Given this list of marker genes Psmb4, Psmd2, Psmd7, Maml3, Psmd3 (proteasome (prosome, macropain) 26S subunit, non-ATPase, 3), Psma3, Lef1, Yap1, Psmb2, Tcf7, Ubc, Tead2, Trp53, Psmc6, Smad3, Mamld1, Psma5, Psmd8, Psmd12, Psma1 (NCBI Gene Id 26440), Psmb1, Hdac4, Notch1 (notch 1), Kat2a, Psma6, Psmd14, Psmd1, Zfhx3, Uba52rt, Rbpj, Smad4, Psmc4, Maml2, Tead1, Psmc2, Smurf1, Rps27a, Psmc5, Psmc3, Psmd6, Tcf7l2, Tcf7l1, Smurf2, Psmd13 (NCBI Gene Id 23997), Tgfb1, Psma7, Ep300, Psmb6, Cbfb, Psma4, Uba52 (NCBI Gene Id 56512), Kat2b, Ctnnb1, Psmc1 (NCBI Gene Id 19179, protease (prosome, macropain) 26S subunit, ATPase 1), Psmd11, Psmb5, Mdm2, Tead4, Psma2, Psmb7, Ccnd1, Tead3, Src, Ubb, Maml1, Runx3, Psmb3, Adrm1, here is a description of the gene set: Mouse Gene Set: REACTOME_TRANSCRIPTIONAL_REGULATION_BY_RUNX3 Transcriptional regulation by RUNX3 species: Mus musculus